The following is a description of a gene set: studied in species Homo sapiens Carbohydrate sulfotransferase 6 (CHST6) catalyzes the transfer of sulfate to position 6 of non-reducing ends of N-acetylglucosamine (GlcNAc) residues on keratan sulfate (KS). KS plays a central role in maintaining corneal transparency. Defective CHST6 results in unsulfated keratan deposited within the intracellular space and the extracellular corneal stroma leading to macular dystrophy, corneal type I (MCDC1; MIM:217800). MCDC1 is an early-onset, ocular disease characterized by bilateral, progressive corneal opacification, and reduced corneal sensitivity (Jones & Zimmerman 1961). MCD can be subdivided into 2 types on the basis of immunohistochemical studies and serum analysis for keratan sulfate; MCD type I, in which there is a virtual absence of sulfated KS-specific antibody response in the serum and cornea and MCD type II, in which the normal KS-specific antibody response is present in cornea and serum. Reactome Pathway: Defective CHST6 causes MCDC1 part of: Diseases associated with glycosaminoglycan metabolism, and this is the list of marker genes: PRELP, OGN, OMD, ACAN, FMOD, CHST6, KERA, LUM (NCBI Gene Id 4060)